Given this list of marker genes Pkp1, Casp8, Casp9, Ywhah, Kpna1, Mapt, Ywhaq, Hmgb2, Hmgb1, Bad, Dcc, Gsdme, Fnta, Stk24, Ptk2, Kpnb1, Rock1, Satb1, Bcap31, Dffb, Bcl2l11, Pmaip1, Stk26, Ywhaz, Bmx, Opa1, Gm10053, H1f0 (NCBI Gene Id 320750), Tnfsf10, Fadd, Ocln, Ctnnb1, Casp3, H1f1, Fas, Bcl2, Cflar, Ticam1, Ppp3cc, Ly96 (lymphocyte antigen 96), Bid, Bax, Dnm1l, Prkcq, Gzmb, Tjp2, Dsp, Apc, Prkcd, Dsg3, Bmf, Cd14, Gas2, Apip, Mapk3, Clspn (NCBI Gene Id 97173), Aven, Ripk1, Sfn, Ywhag, Dynll1, Appl1, Diablo, Lmnb1, Tlr4, Gsdmd, Sorbs2, Bcl2l1, Add1, Acin1, Mapk1, Dffa, Oma1, Casp7, Septin4, Plec, Traf2, Ywhae, Dsg2, Casp6, Apaf1, Tradd, Ywhab, Xiap, Ticam2 (TIR domain containing adaptor molecule 2), Cycs, Vim, Nmt1, Bak1, Mapk8, Lmna, Dynll2, Tnfrsf10b, H1f5 (NCBI Gene Id 56702), Ppp3r1, H1f2, Gsn, Birc2, Fasl, H1f4, Sptan1, Dsg1a, Tjp1, here is a description of the gene set: Apoptosis Mouse Gene Set: REACTOME_APOPTOSIS species: Mus musculus